The following is a description of a gene set: Binding to a member of the bone morphogenetic protein (BMP) family. studied in species Homo sapiens Human Gene Set: GOMF_BMP_BINDING, and this is the list of marker genes: UCMA, CHRDL2, CHRD, SOSTDC1, GREM1, GDF5, TCAP, CER1, BMPR1B, COMP, BMPR1A, ENG, TGFBR3, BMPR2, NBL1, CHRDL1, MICOS10-NBL1, HJV, SCUBE3, SOST, GREM2